Given this list of marker genes CAMK2D, MAP2K1, SHOC2, RAP1A (NCBI Gene Id 5906), CNKSR1, RAF1 (NCBI Gene Id 5894), LMNA, AGK (acylglycerol kinase), CAMK2B, ARRB2, DUSP8, SRC, TENT4A (NCBI Gene Id 11044), AGGF1, ACTB, FN1, MAP2K2, CSK, APBB1IP, FGB (fibrinogen beta chain), CALM1, TRAK1, DUSP10, BRAP, FGA (fibrinogen alpha chain), FAM114A2, HRAS, KSR1, AKAP9, ITGA2B, SND1, DUSP16, ITGB3, FXR1, MRAS, PAPSS1, ZC3HAV1, MPRIP, DUSP7, KDM7A, RAP1B, CAMK2G, PPP1CC, PHB1, CAMK2A, KSR2, ATG7, KIAA1549, CLCN6, DUSP6, TLN1, FGG, TRIM24, YWHAB, PPP1CB, ESRP1, QKI, ARAF, SPRED3, BRAF, VCL, ARRB1, ACTG1, AP3B1, JAK2, NRAS, CNKSR2, FAM131B, IQGAP1, AGTRAP, DUSP9, SPRED2, VWF, MAPK1, MAP3K11, SPRED1, KRAS, PEBP1, MAPK3, NF1, MARK3, BCL2L11, here is a description of the gene set: Reactome Pathway: Oncogenic MAPK signaling part of: Diseases of signal transduction by growth factor receptors and second messengers The importance of the RAS/RAF/MAPK cascade in regulating cellular proliferation, differentiation and survival is highlighted by the fact that components of the pathway are mutated with high frequency in a large number of human cancers. Activating mutations in RAS are found in approximately one third of human cancers, while ~8% of tumors express an activated form of BRAF. RAS pathway activation is also achieved in a smaller subset of cancers by loss-of-function mutations in negative regulators of RAS signaling, such as the RAS GAP NF1. studied in species Homo sapiens